Given this list of marker genes Vps41, Hook1, Vps8, Vps18, Stx17, Vps39, Hook3, Vps33b, Vps16, Vps11, Vps33a, Hook2, Aktip, here is a description of the gene set: species: Mus musculus A multimeric protein complex that associates with the vacuolar membrane, late endosomal (multivesicular body) and lysosomal membranes. HOPS is a tethering complex involved in vesicle fusion. Mouse Gene Set: GOCC_HOPS_COMPLEX